The following is a description of a gene set: species: Homo sapiens Phase I biotransformations, non-P450 Human Gene Set: WP_PHASE_I_BIOTRANSFORMATIONS_NONP450, and this is the list of marker genes: PON2, ESD, CES1, PON3, PON1, CES5A, LIPA, CES2